The following is a description of a gene set: Abnormal nasal morphology Human Gene Set: HP_ABNORMAL_NASAL_MORPHOLOGY studied in species Homo sapiens, and this is the list of marker genes: WBP11 (NCBI Gene Id 51729), GLMN, PPP1R12A, LARP7, RAB3GAP2, KANSL1, HYDIN, ZMIZ1, TCF4, CPT2, NFASC, TP63, VPS53, ACY1, COLEC10, WDPCP, SUFU, MYT1L, TRPV4, TMEM53, POLD1, RTL1, NF1, TOPORS, FLNA, MTHFR, CHST3, KISS1, INSR (insulin receptor), NGLY1, MICU1, GATAD2B, SKIC3 (NCBI Gene Id 9652), NKX2-6, WNT9B, ANKH, HMGA2, TAP2, TGIF1, RPL8, PUS7, FKBP6, SHOC2, PEX1, XRCC4, ZNF423, BTNL2, EDNRA, MYCN, SRD5A3, GPC4, TXNDC15 (NCBI Gene Id 79770), JARID2, RET, BCAS3 (NCBI Gene Id 89751), TRIM32, U2AF2, PDGFRB (platelet derived growth factor receptor beta), CFAP221, CANT1, PCLO, OTUD6B, MESP2, TBC1D24 (TBC1 domain family member 24), AFF2, PAX3, AFF3, TTC8, KDR, CKAP2L, DNAAF2, DSE, CRIPT, GABRA3, IFT56, HYMAI, CNTNAP2, KLHL15, DVL1, C1GALT1C1, TMLHE, IFT122, NODAL (NCBI Gene Id 8114), DNAAF11, TPR, RPL35, METTL23, STXBP1, LAMA5, NUDT2, WDR73, COLEC11, AP1S2, PCNT, KNL1, BRAF, GFRA1, EDA, RAB23, DDR2, EBF3, RBM8A, ACTL6B, AASS, MMP23B, EP300, MACF1, ZNF668, TEFM, PDPN (NCBI Gene Id 29912), USB1, TCOF1, RAPSN, FUT8, MEGF8, ANK1, POLR3A, CHSY1 (NCBI Gene Id 22856), EYA1, AP2M1, BBIP1, IRF6, RPS15A, FLT4, NR2F1, TRMT1, FILIP1, SIM1, SOX3, SMC5, AARS1 (alanyl-tRNA synthetase 1), PEPD, TPO, POU1F1, PUM1, ALG3, HERC2, PIBF1, STRA6, SUPT16H, IFT81, SMCHD1, RPL18, TSR2, TAOK1, SMARCB1, GAS1, RNF2, PWRN1, ZMYND10, ALDH1A2, PSMC1, RNF125, QARS1, GATA5, COG4, CFAP418, TSHB, BMPR1A, SCLT1, OCLN, COG1, ACAN, TCTN2, ODAD2, LRPPRC, POLE (NCBI Gene Id 80252), NEUROD2, LETM1, NDUFB11, ACBD6, RPS20, FGD1, SLC6A9, LTBP3, POLA1, ECE1, EHMT1, B3GAT3, PRMT7, AKT3, FOCAD, TMCO1, CEP41, ETFB, GATA4, FLNB, ZEB2, KDF1, MAFB, EZH2, FMR1, COL5A1, OFD1, CDH2, TWIST2, PACS1, MAP3K7, NMNAT1, KCNN4, LMX1B, SCN1B, PLK4, KDM1A, PIGG, PEX12, NARS2, PHGDH, FANCA, SLC12A2, BRCA1, TENT5A, NACC1, EDN3, RPL27, DONSON, DPH5, PIGQ, CAV1, H4C3, KCNJ2, SLC39A13, NIN, FOXG1, MPDZ, HSD17B4, AXIN1, AIFM1 (NCBI Gene Id 9131), MBTPS2, SON, CC2D2A, TREX1, ANKRD11, SLC18A3, SCUBE3, DNAAF6, FIG4, MARS2, GNPAT, SOX4 (NCBI Gene Id 6659), SHOX, TMEM231, TCTN3, ACP5, CEACAM6, COL11A2, COL3A1, SNRPN, SLC35A2, GDF5, TBCE, PIGS, UBR1, PLXNA1, RPS26, MINPP1, FOXH1, PIGV, MRPS14, LUZP1, MAD2L2, MED12L, TRIP12, GTF2I, HDAC4, RPL35A (NCBI Gene Id 6165), TMEM270, RPGRIP1L, PIGB (NCBI Gene Id 9488), PGAP2, CHRNG, PCGF2, APC2, SYNE1, PTPN11, DCHS1, EDAR, DNAI2, ABCC9, RPL9, MED13, PLOD3, SLC17A5, AP4E1, KIF21A, NRCAM, ITCH, RMRP, MIA3, TLK2, POLR1D, SF3B4, BMP2, HES7, RAB18, UFC1, ADAMTSL2, CSPP1, STIM1, CENPT, ENG, ECEL1, TAPT1, SLC11A1, DYRK1A, TBX21, CCDC40, ADAMTS2, DISP1, CSGALNACT1, WDR37, PPM1B, CAPN15, TACR3, KAT5, PEX10, STAT5B, FHL1, BBS1, RAC3, RBM10, ODAD4, PGAP3, GTF2IRD2 (GTF2I repeat domain containing 2), PYCR1, NOVA2, COX4I1, THOC6, DRC1, HDAC6, EMG1, METTL27, TCTN1, STK11, ATR, XPC, DHODH, CCNK, CHRNA1, AIP, AFG2A, SLC2A10, ODC1, CCDC47, CCDC8, SMG9, TBCK, PTEN, ASXL3, NPHP1, JMJD1C, ERCC2, ADAT3, RAB34 (RAB34, member RAS oncogene family), DPYD, DYNC1I2, WNT5A, DNA2, BCL11B, BLM, EFTUD2, SMAD4, CHD5, NCF1, PTPN14, FGF20, CLIP2, RPS23 (NCBI Gene Id 6228), TUBGCP2, PIGN, POLR1C, COL18A1, SKI, SALL4, OTX2 (NCBI Gene Id 5015), GNB2, TOR1A, ALX3, CPSF3, RAC1, CARS1, SETD5, PIGL, DNMT3B, BBS12, TMEM70, SOX11, UBE4B, XPA, ODAD1, HLA-DRB1, TRRAP, ACTG1 (NCBI Gene Id 71), PEX11B, TBL1XR1, BRPF1, WNK3, SERPINA1, GREB1L, BBS4, PGM2L1, WASHC5, PHIP, TRPS1, BPTF, CFAP298, KCNN3, ADAMTS3, DICER1, ATIC (NCBI Gene Id 471), DGCR8, UHRF1, PAICS, SDCCAG8, TGFB1, NME8, FANCG, KCNJ5, CSF1R, STX16, GNS, BCOR, EED, ARVCF, RPS29, ARSK, DNAJB13, AP3B1, MITF, PAM16, FOXP2, AHSG, TOE1, SIK1, PLEC, POLR1A, KDM6B, GPC6, TBX2, MDM2 (MDM2 proto-oncogene), WWOX, PAX7, ATAD3A, RPL31, COL2A1, VPS37D, ADNP, BMPER, OPHN1, MAPRE2, B3GALT6, TMEM94, KCNH1, DNAL1, PIK3R2, FBXO31, PIK3R1, IL1RAPL1, IDUA, CLP1, PPM1D, BNC2, MCOLN1, ERI1, SLC29A3, PARS2, ACVRL1, BCAP31 (NCBI Gene Id 10134), FRMD4A, MAF, RPGRIP1, ALG12, TPM2, EXT2, HEPACAM, RPS17, KCNJ11, PCDHGC4, H4C9, PBX1, KIAA0586, FRAS1, KMT2A, SCAF4, CEP57, DOCK7 (NCBI Gene Id 85440), DCAF17, NPAP1, SMOC1, SMARCA2, KIT, TMEM107, CFTR, FTSJ1, FGF10 (NCBI Gene Id 2255), USP9X, TRAF7, GNRH1, SVBP, MOCS1, FGF17, BBS10, NME5, ARID1B, ESCO2, SCNM1, SUMF1, TTC12, IFT80, GSTM3, FGF8, PAX1 (NCBI Gene Id 5075), IDS, CRKL, PEX19, YARS2, CHRND, SOX5, EDA2R, FANCI, CNOT2 (CCR4-NOT transcription complex subunit 2), STAG1, PTCH1, PPP2CA, MOCS2, CHD2, FOXC1, CUX1, EDARADD, RYR3, DNAJC30, PIGP, RSRC1, TMEM216, TMEM237, GAS2L2, ASH1L, GDF1, RNU7-1, RSPH1, ADAMTS18, BRD4, SYT1, CDC42BPB, MTOR, PEX7, PTH1R, B4GALT1, DGCR2, MYRF, SLX4, PDE4D, TBX4, IFIH1, DYNC2LI1, LEMD3, SLC6A1, ERCC3, RPS7, GRIP1 (glutamate receptor interacting protein 1), GNAI1, SMO, MAB21L1, STAT3, MESD, UMPS, LIG4, GNPNAT1, MUSK, KDM4B, STT3A, SPECC1L, SMPD4, PRKCZ, FTO, BBS7, FANCD2, GLB1, KREMEN1, CAMKMT, ATN1, MYMX, DOCK6, THUMPD1, ALG9, NKX2-5 (NCBI Gene Id 1482), ADAMTSL1, KIFBP, CENPF, SCARF2, OBSL1, CHD6, SNORD115-1, RERE, SCYL2, RAF1, SIN3A, TFE3, PRKACA, NHS, SIX3, SLC1A4, HNRNPK, BPNT2, HIRA, SOX10 (SRY-box transcription factor 10), RNASEH2C, NSRP1, TUBGCP4, ZNHIT3, ZNF699, SETD1A, CLCF1, C2CD3, H4C11, ARSB, DHX9, DDB1, NEDD4L, PDHA1, GJA5, FRMPD4, PITX2, CCNQ, STAMBP, LMNA, UNC119, PSMD12, PUS1, LRRC56, RSPH9 (radial spoke head component 9), GRIN1, GOLGA2, ITGA8, FAM149B1, ADGRG6, ERCC5, SPAG1, MAGEL2, DVL3, IGBP1, NUP85, FANCF, DNAAF1, GRIN2A, WDR19, SLC37A4, STRADA, RB1, FH, TWIST1, NSMF, DBR1, PPP2R1A, HNRNPR, LZTFL1, FZD2, FANCM, ZNF341 (zinc finger protein 341), ZIC2, MTX2, RAP1GDS1 (Rap1 GTPase-GDP dissociation stimulator 1), NSMCE3, NDP, AGO2, DHX30, LHX4, AFG2B, ETFA, PREPL, SCN1A, AP4B1, KPTN, PPP1R15B, PRRX1, COG5, KLHL7, RAI1, ALDH6A1, COL11A1, DDB2, RHOA, TAF4, ROR2, KIF15, COL9A3, ZNF335, HNRNPH2, SMAD2, ELN, TUBA1A, KDM3B, ORC6, RTTN, DOK7, UQCC2, UBE2A, WBP4, FAM20C, ASNS, CCND2, RELN, PEX2, CUL4B, ARL6, DCPS, MYO18B, ZNF148, MED12, HOXB1, DOCK3 (NCBI Gene Id 1795), GPX4, MKRN3, RALGAPA1, PIK3CA, FOXE1, SYNGAP1, PEX6, FLII, PORCN, ERCC6, MIPEP, UGP2, KIAA0753, TRIP11, LAS1L, SOX18, PRDM16, BBS5, TGFB3, PIGY, TONSL, NEPRO, PTCH2, PPP2R3C, WDR4, WAC, DYNC2I2, RPGR, HERC1, SP7, SETBP1, STK36, EDNRB, RAB3GAP1, FLCN, HESX1, FOXJ1, PACS2, MED27, AMER1, DYNC2I1, CAPRIN1, FANCE, KAT6B (lysine acetyltransferase 6B), GP1BB, ERCC8, CTNNB1, AMMECR1, H3-3B, TMEM138, P4HTM, NPR2, AGA, RPL5, KCNK9, TXNL4A, IL2RA, INTU (inturned planar cell polarity protein), WDR62, TUBGCP6, DNAH5, CCNO, PPP1R21, LIFR, SLC3A1, SNAP29, LMNB1, ATP6V1E1, MSX1, SEMA5A, RALA, MOGS, ATP7A, SLC4A10, IER3IP1, PIGW, RDH11, CILK1 (ciliogenesis associated kinase 1), CERT1, MGP, RPS6KA3, DPH2, MYMK, RPS27, RAP1B, FCGR2A, TRAIP, IFT172, AP4S1, INTS1, POGZ, CHD3, DHX37, PUF60, TRPV6, ADA2, POLG2, CTBP1, PKDCC, LTBP1, CDCA7 (cell division cycle associated 7), SH2B1, RBBP8, KCNJ6, SLC2A1, BCKDK, AIRE, GPAA1 (glycosylphosphatidylinositol anchor attachment 1), RREB1, CHD7, ATP6V1A, CHRNA7, PLAAT3, PRIM1, CTSD, KCNAB2 (potassium voltage-gated channel subfamily A regulatory beta subunit 2), GAD1, RLIM, RHOBTB2, NECTIN1 (NCBI Gene Id 84853), SPINT2, ADAMTS10, CLPB, PGAP1, TMEM67, MAPK1, ZSWIM6, EFEMP2, TBX1, SLC9A6, TRIP13, HDAC8, CACNA1G, EXT1, PEX16 (peroxisomal biogenesis factor 16), MEIS2, TGDS, CEP295, HPDL, PMM2, ESS2, DLX4 (distal-less homeobox 4), JAG1, DPYSL5, CDH11, SMC3, MAPK8IP3, RPL10, ALX4, SHANK3, GCSH, DUOXA2, MKKS, SLC32A1, SRCAP, BLTP1, KCNA1, FGFR3, LRP4, ATP6V0A2, SPTBN1, RUNX2 (RUNX family transcription factor 2), KDM5A, DPH1, RUSC2, IFT43, FGFR1, DNAH9, NHLH2, RFX7, BUB3, SC5D (sterol-C5-desaturase), PWAR1, RNASEH2A, CAMTA1, ANTXR1, ZNF292, HECW2, NEXMIF, FOXL2, AKT1, DPF2, RNF135, FBN1, VARS1, GNAS, NOG, ABCA12, TOGARAM1, GNPTAB, TBC1D20, CDKL5, TNNI2, SNIP1, CBY1 (NCBI Gene Id 25776), GATA6, AHDC1, SLC25A46, TUBB, IFT52, CASP2, FANCL, PRKACB, IPO8, GMNN, PAFAH1B1, GDF2, EIF2S3, SLC9A3, CCDC39, IFT74, WASHC4, PRKAR1B, KRAS, MAN1B1, TAC3, CUL7, SKIC2, EIF2AK3, PLA2G6, DNAAF3, ATPAF2, SMARCAL1, SRPX2, NANS, DLK1, RIPK4, RPL26 (NCBI Gene Id 6154), MEG3, SEC23A, TCF3, NSDHL, DHCR24, ARMC9, DNAAF5 (dynein axonemal assembly factor 5), PIEZO2, BUD23, SRRM2, ALDH18A1, TRAF6, FAT4, ABCD1, NEK1, POLR1B, DPM1, NUP188, FGF3, HCCS, PLAA, NEK10, COL1A1, GPR101, HNRNPH1, GBA1, CWC27, ACTG2, CACNA1C, ZC4H2, PROP1, GTF2IRD1, SETD2, SCAPER, SMC1A, B9D2, PAH (phenylalanine hydroxylase), CCDC88A, HK1, RIPPLY2, KCNMA1, TRAPPC9, RBMX (NCBI Gene Id 8258), SPART, LZTR1 (NCBI Gene Id 8216), UBE3B, ECM1, FANCC, PI4KA, ERCC4, NFKBIA, PIGO, HYAL1, GNE, EXTL3, WNT3, EBP, CDK5RAP2, ARSL, DPM2, PIGF, CFAP74, TNNT3, HYOU1, HBA1, MEF2C, NSUN2, PITX1, PIGT, RSPRY1, NHEJ1, SMARCD1, CLCA4, PRPS1, CBL, IFT27, MPLKIP, BICRA, YY1, PQBP1 (NCBI Gene Id 5974), SLC25A22, GRM7, SLC45A1, CHD8, EFNB1, TNPO2, FBXL4, PROK2, EPG5, DUOX2 (dual oxidase 2), NAA10, EIF4A3, PEX14, SLC26A2, CEP104, VPS35L, NOTCH2, ALG2, UNC80, CEACAM3, RNF13, SMARCA4, BMP4, MLXIPL, CRELD1, CENPJ, CHN1, NFIX, SLF2, ATP6V1B2, COG8, SLC35C1, WARS1, NALCN, KNSTRN, MVK, ASXL2, CDK19, DNAH1, IFT57, TBCD, HFE, ARX, GLI3, EXOSC5, DUSP6, TAF1, MAP2K1, MADD, ZFPM2, ORC4, PEX13, SAMHD1, SNORD116-1 (small nucleolar RNA, C/D box 116-1), ARL13B (NCBI Gene Id 200894), ABCA5, ZMYM2, KDM5B, PNKP, TCF20, ARID2, MECP2, H3-3A, KYNU, CACNA1B, PAK3 (NCBI Gene Id 5063), EIF4A2, TBL2, CHST14, LMBR1, ADSL, STING1, ZNF462, POLRMT, MID1, CDH1, NELFA (NCBI Gene Id 7469), BCR, RARB, FLI1, ALG13, BAZ1B, NCAPG2, SCN4A, VANGL2, DYNC2H1, CENPE, KISS1R, MIF, CTSK, BRF1, IL11RA, CRIPTO, MAN2C1, GMPPA, CDC45, SET, DRG1, KCNJ8 (potassium inwardly rectifying channel subfamily J member 8), AVP, PYCR2, LINS1, PPP3CA, IGF1, GABRD, CASZ1, SHH, PURA, SLC5A5, FANCB, UBA1, UFD1, TTC5, RYR1, FBXL3, ZDHHC9, RECQL, CLIC2, PIGU, GDF11, FOXA2, APC, SPEF2, RBL2, DLL1, BANF1, GLUL, RIC1, HEATR3, GCLC, PTF1A, SMS, HIC1, SLC12A6, CRLF1, MIR140, XYLT1, ADGRG1, CEP120, DZIP1L, PPP1R13L (NCBI Gene Id 23453), COL27A1, HS2ST1, ITGA3, FGFR2, TTI2, TBX6, GPRASP2, NUP88, INPPL1, PAK2, KMT5B, DDX3X, CEP290, NOTCH3, IQSEC2, SH3PXD2B, PIGA, SPOP, VPS13B, MMP2, COX7B, GJA1, KDM5C, SALL1, FDFT1, MASP1, AGL, FAR1, RPL11, CFAP300, HIVEP2, CSNK2A1, RNU4-2, ATRIP, NBN, ACSL4, CCN2, C12orf57, LRP2, KAT6A, RPL15, WDR26, CDC42, TFAP2A, MBD5 (methyl-CpG binding domain protein 5), NSD2, B9D1, MYOD1, TRMT10A, COG6, MKS1, LHX3, MSL3, ZFX, VPS33A, YARS1, PALB2, DNMT3A, DNAH11, EXOSC2, UPF3B (UPF3B regulator of nonsense mediated mRNA decay), LBR, POU4F1, INPP5E, TFAP2B, METTL5, FBXO28, GNRHR, GLIS3, KIF14, PRKD1, RARS2, RAD51C, CTNND2, ETFDH (NCBI Gene Id 2110), KCTD1, GGCX, CDON, RNU4ATAC, NEU1, AFF4, WNT7A, GLI2, HMOX1, BUB1B (BUB1 mitotic checkpoint serine/threonine kinase B), KATNIP, RIN2, RSPO2, PLOD1, PIK3C2A (phosphatidylinositol-4-phosphate 3-kinase catalytic subunit type 2 alpha), BUB1, FUCA1, ITGB6, POMGNT1, WDR11, TRIO, MPV17, RNASEH2B, FOXP1, ACER3, ERF, G6PC3, DHCR7, ADAR, LSS, MN1, HYLS1, CIT (citron rho-interacting serine/threonine kinase), WLS, NXN, NKX6-2, PTPRF, FREM1, VAC14, NAGA, EPCAM, ZMPSTE24, TAF6, FGFRL1, CITED2, NIPBL, MGAT2, SEPTIN9 (NCBI Gene Id 8162), B4GALT7, CDK13 (NCBI Gene Id 8621), CHMP1A, SOST, PSMB8, DNAI1 (dynein axonemal intermediate chain 1), PEX3, COMT, SHROOM4, KIF11, EEF1A2, TOMM7, CLTCL1, BCL11A, IFT140, GTPBP2, LONP1, GNAO1 (G protein subunit alpha o1), HELLS, RECQL4, GABBR1, CNOT1, CEP152, GRIN2B, LSM11, STIL, SPRY4, CPLX1, HSPG2, B3GLCT, RPS19, TMEM147, POC1A, PDE6D, GATA1, TRIM37, RAD21, WARS2, LTBP4, TALDO1, QRICH1, GJA8, ACTB, CDK10, SOS1, FBXO11, TASP1, RPS10, UBAP2L, IGF1R, CEP55, BMPR1B, ZBTB24, HBA2, CCDC22, SLC25A24, COG7, DGCR6, WDR35, GH1, ITPR1, IRX5, BBS9, SIX2, AIMP2, H4C5, SPRED2, IL6ST, ERCC1, PIK3CD, RFC2, PERCC1, VDR, ALX1, AGO1, PHF21A, EIF4H, DMXL2, TAP1, SUZ12, HBB, NFIA, AP4M1, PLCB3, COL1A2, EXOC2 (NCBI Gene Id 55770), IYD, PTGER2 (prostaglandin E receptor 2), ARL3, ZBTB20, YWHAE (tyrosine 3-monooxygenase/tryptophan 5-monooxygenase activation protein epsilon), SCO2, CDKN1C, MYH3, GHR, SMARCE1, CPLANE1, NUAK2, RAD51, KMT2B, KDM6A, MRAS, SNX14, HSPA9, LIMK1, GPC3, HECTD4, CCBE1, TRPM3, RSPH3, SCN2A, MCIDAS, NSD1, MAP2K2, SNAI2, ANKRD17, DEAF1, ARID1A, AHI1, RSPH4A, BCORL1, STX1A, SLC6A14, ZPR1, SMG8, CLCN3, MCTP2, PRKG2 (NCBI Gene Id 5593), LFNG, ASXL1, GALNT2, CNOT3, CTU2, DHPS, BBS2, HUWE1 (NCBI Gene Id 54789), KATNB1, BRCA2, PROKR2, UBE2T, MDH1, KAT8, SATB2, NDE1, DIS3L2, ASPH, IARS2, MAPKAPK5, MED13L, TSPEAR, BRCC3, SLC26A9, TRIM8, SEMA3E, ODAD3, RFWD3, CAMSAP1, ASCC3, HNRNPC, CTCF, CD96 (NCBI Gene Id 337949), CASK, NONO (non-POU domain containing octamer binding), EDEM3, KCNE5, FREM2, CREBBP, DNAAF4, SMARCC2, PRKDC, RPS24, ZNF526, BAP1, FRA10AC1, PTDSS1, KIF7, PKHD1 (NCBI Gene Id 5314), USH1G, ZBTB18, COG3, INTS11, RPS28, PPP1CB, SPEN, KMT2D, XRCC2, PRKAR1A, WRN, NRAS, POR, PHF8, PSAT1 (phosphoserine aminotransferase 1), PPP2R5D, EXOSC1, NFIB (NCBI Gene Id 4781), AUTS2, SPRTN, SOX9, VPS51, TBC1D23, ABCC8, SOX6, THSD1, ACOX1, DLL3, CEP19, PEX26, HS6ST1, TG, SEC24C, PLAGL1, ABL1, ESAM, MAN2B1, PLCH1, EIF5A, STAG2, BRIP1, NEK9, PEX5, LEMD2, TMEM218, SLC35D1, LMBRD2, DCTN4 (NCBI Gene Id 51164), HRAS, MED25, DENND5A, ATRX